The following is a description of a gene set: Aberrant signaling by activated forms of FLT3 can be inhibited by tyrosine kinase inhibitors (TKIs). FLT3 receptors are class III receptor tyrosine kinase receptors, also known as dual-switch. Dual-switch receptors are activated through a series of phosphorylation and conformational changes that move the receptor from the inactive form to the fully activated form. Type II TKIs bind to the inactive form of the receptor at a site adjacent to the ATP-binding cleft, while type I TKIs bind to the active form.<br><br>FLT3 internal tandem duplications (ITDs) are found in ~25-30% of acute myeloid leukemias, and are present at lower frequencies in other cancers. These ITDs generally occur in a tyrosine-rich region of exon 14, encoding the juxtamembrane domain region of the protein; at a lower frequency, ITDs are found in the first tyrosine kinase domain (TKD1). In addition to ITDs, a number of point mutations in the juxtamembrane domain have also been identified. Juxtamembrane domain mutations affect an autoinhibitory loop, shifting the equilibrium of the receptor towards the activated state; despite this, however, juxtamembrane domain mutants remain predominantly in the inactive state and as such are susceptible to inhibition by type II TKIs. <br><br>Activation loop mutations more strongly favor the active conformation of the receptor and are susceptible to inhibition by both type II and type I TKIs. The most prevalent FLT3 mutation, D835Y, promotes the active conformation strongly enough to be resistant to type II TKIs. part of: FLT3 signaling in disease Reactome Pathway: FLT3 mutants bind TKIs species: Homo sapiens, and this is the list of marker genes: FLT3